Given this list of marker genes Ceacam1, Cd34, Rap1a, Ramp2, Adm, Rras, Rapgef2, Asb4, Rin2, Kdr, Tmem100, here is a description of the gene set: species: Mus musculus Mouse Gene Set: GOBP_POSITIVE_REGULATION_OF_VASCULOGENESIS Any process that activates or increases the frequency, rate or extent of vasculogenesis.